The following is a description of a gene set: studied in species Mus musculus The portion of endoplasmic reticulum, the intracellular network of tubules and cisternae, that occurs near the nucleus. The lumen of the perinuclear endoplasmic reticulum is contiguous with the nuclear envelope lumen (also called perinuclear space), the region between the inner and outer nuclear membranes. Mouse Gene Set: GOCC_PERINUCLEAR_ENDOPLASMIC_RETICULUM, and this is the list of marker genes: Clu, Osbpl6, Cybb (NCBI Gene Id 97621), Gdpd5, Dst, Nox4, Kcnd3, Trim13, Osbp2, Capn2, Pik3r1, Osbpl1a, Bcap31, Cyba, Sec23ip, Creb3l2, Osbpl3, Osbpl2, Dbi, Dgat2, Cisd2, Kcnd2, Adam10, Osbp, Osbpl7, Fyn, Mogat2, Syt6